Given this list of marker genes PYCR1 (NCBI Gene Id 5831), TFAP4 (NCBI Gene Id 7023), RBM42, APOC1, RFC4, H2AX, HIC2, POLRMT, ACSL3, S100A11, NUP205, TOP2A, UBE2M, MTHFD1, MRPS27, HMGN4, GMPS, G0S2, CAD, DDX1, CCND3, PSPH, SDHB (succinate dehydrogenase complex iron sulfur subunit B, NCBI Gene Id 96200), PCNA, HSD17B10, VRK1, SMC1A, DHRS3, DHX9, TYMS, APOE (NCBI Gene Id 99), MCM3, CDC20, CCT6A, CIAO1, SNRPB2, MTREX, ARL4A, CTSC, SNRPF, NUP153, IGF1, SLC1A5, CELF2, INPPL1, EIF2S3, TIMM17B, AIMP2, HMMR, PIM2, ZWINT, EXOSC8, SEC13, DTYMK, NAP1L1, RTCA, LSM14A, EIF3I, PSMA4, NHP2, HSF1, PDCD10, AK2, SNRPC, HHEX, TTK, MRPL47, LMO2, ZYX, PTP4A3, APRT, H2BC12, METAP1, SNCG, SCP2, SLC4A2, MAGEA3, ALG8, ADIPOR2, UBXN1, RPA3, VAMP7, VDAC2, IL27RA, CBX3, MRPL12, PAICS, GAGE12F, TRIB2, CDC45, P4HA1, IER3 (immediate early response 3), PSPHP1, NDUFS2, KLHDC3, TMX1, MAPRE1, MRPL3, PRSS2, EBP, DDX21, LMNB2, NMU, MLLT11, GET1, IGBP1, LDLR, DNM2, PPP4C (protein phosphatase 4 catalytic subunit), RAC3, DAP3, MRPS12, CSH2, VSIG4, AHCYL1, H1-2, HOXB2, MRPL40 (mitochondrial ribosomal protein L40), UBE2L6, ACAT2, TUSC3, COPS2, MCM7, GOT1, PSMC6, PPP2R2A, IL2RG, MTA1, GTF2A2, SHMT2, EIF5, GJB1, BLMH, FDFT1, MYB, PTPRC, COPS3, SQLE, PSMA3, DLK1, PRSS3, CKAP5, MSH2, CLPP, PLK1, VBP1, GNL2, CKS2, ZNHIT3, LTBR (lymphotoxin beta receptor), GATA1, SRPRA, SF3A2, EEF1E1, NECAB3, SORD, IGF2BP3, PRAME, KRT18, INSIG1 (insulin induced gene 1), ACOT7, PNP, POLD2, ALDH1A2, GADD45A, TBCE (tubulin folding cofactor E), H2AC6, RRP1B, PSMB7, ZBTB5, CYP2F1, PSMD14, GATA2, PRPF40A, H2BC21, KIF14, LAPTM5, BMS1, SEC24C (SEC24 homolog C, COPII coat complex component), PRPF19, IPO7, PIM1, COX7B, CCT4, CDC34, AKR1C1, PSMC4, RHOG, CDK1, RBBP4, ACBD3, DNMT1, GTF2E2, PTPN12, NUDT1, UGCG, ITGB3BP, TRIP13, GDF15, HMGCS1, ARID3A, APOBEC3B, C5orf15, HPRT1, BYSL (NCBI Gene Id 705), DDIT3, NMI, PHLDA2, DDIT4, TRAPPC6A, SMARCA4, ZNF451, POLE3, ITPR3, SMS, PRKCB, HES1, CYB5B (NCBI Gene Id 80777), ANGPT1, ST6GAL1, PTTG1, SRP19, TOMM40, SRP54, H2BC13, NPC1, KDM5C, CCNB1, RCC1, ECI1, TNNT1, CD3D, FADS1, PRKDC, SSBP1, NFE2L2, ANXA1, SRPK1, CDK16, TMEM158, SLC29A1, CCNG1, SLC2A3, AP1M1, COLGALT2, SRSF2, MCM6, TNFRSF10B, MBD4, KRT19, NUP93, PSMG1, PPP2R5D, TGM2, RIDA, SF3A3, SEC11A, PSMC2, CHPF, H2BC11, SLC7A5, KRT4, CDK2, MAPK6, GSPT1, FDPS, UCK2 (NCBI Gene Id 7371), PYGL, PSMD4 (NCBI Gene Id 5710), PKMYT1, IGFBP4, TK1, FEN1, EMP3, CD24, CHAF1A, PES1, MYC, ZNF175, APEX1, TCF12, RBCK1, TFRC, MCM2, PCLAF, MAGEA2 (NCBI Gene Id 83160), STMN1, CCNB2, DARS1, MARCHF6, CRYZ, LRPPRC, MSMO1 (NCBI Gene Id 6307), BCL2L1, SERPINH1 (NCBI Gene Id 89588), SNRPA1, RARS1, CFHR1, RNASEH2A, JUNB, MDK, NNMT, SF3A1, ITGB5, ABCF1, AHCY, TPX2, DECR1 (2,4-dienoyl-CoA reductase 1), NDUFS6, GFPT1, RBBP7, HMGCR, GAGE12G, FKBP8, IFT25, RRP9, KIF2C, CALU, IARS2, CCNA2, BOP1, DDX39A, SLC25A46, ISG15, NOLC1 (nucleolar and coiled-body phosphoprotein 1), CSNK2A1, TMEM259, GART (phosphoribosylglycinamide formyltransferase, phosphoribosylglycinamide synthetase, phosphoribosylaminoimidazole synthetase), RGS10, SSR1, ATIC, MCFD2, ILF3, EIF4EBP1, SLC43A1, CLN3, LPCAT1, SNW1, CDC42EP1, RANGAP1, COL15A1, ASNS, DDX11, PIGC, VEGFA, COPS5, DHX30, LSM7, AURKB, RAC2, TRPC4AP, DPH2, LSM3, DDHD2, ZIC2, IMMT, WEE1, TMED3, RNPEP, BLVRB, TCAP, ORC1, SRRM2 (serine/arginine repetitive matrix 2), KHDC4, PRIM1, EZH2, here is a description of the gene set: Genes in the cancer module 17. species: Homo sapiens Human Gene Set: MODULE_17